Given this list of marker genes Gss, Ggt6, Aasdh, Slc7a11, Gclm, Ggt1, Slc1a1, Bdh2, Cryaa, Mgst2, Ggt7, Hagh, Nfe2l2, Eif2ak3, Ggt5, Gclc, Slc1a2, here is a description of the gene set: species: Mus musculus The biosynthetic process in which peptide bond formation occurs in the absence of the translational machinery. Examples include the synthesis of antibiotic peptides, and glutathione. Mouse Gene Set: GOBP_NONRIBOSOMAL_PEPTIDE_BIOSYNTHETIC_PROCESS